Given this list of marker genes BDKRB2, BAK1, MIR146A, NOL3, SGK3, MIR222, HELLS, BOK (NCBI Gene Id 84558), PARK7, WFS1, NFE2L2, MMP9, TMEM161A, MAP2K1, SCRT2, SLC25A31, IL1B, USP47, TAF9, HSPA1B, ACVR1, TNF, RIPK1, PTTG1IP, DDIAS, C8orf44-SGK3, PPIA (NCBI Gene Id 5478), CTNNB1, TMBIM6, PEA15, ITGA6, TRIM32, PPIF, CTTN, MIR92A1, FGF2, QARS1, SYVN1, MIR21, RELA, RPS6KB1, BCL2L1, CTH, CSNK2A1, IKBKG, HTRA2, BMI1, PSMD10, TMBIM1, GHITM, GATA4, GDNF, TPT1, MIR19A, PINK1, MDM2, CTNNA1, STRADB, MARCHF7, WNT4, MAP2K5, ARHGEF2, MUC1, PLAUR, URI1, SH3RF1, HMOX1, ITGAV, PIK3CB, ELL3, BCL2, HIF1A, PELI3, GSTP1, IL7, NOC2L, CX3CR1, SRC, BID, ATAD5, TRAP1, DDX3X, ASAH2, NME5 (NME/NM23 family member 5), MIF, CSNK2A2, SERPINE1, CXCL12 (NCBI Gene Id 6387), FZD1, GPX1, HMGB2, BAX, PDX1, YBX3, COL2A1, OPA1, MIR199A1, SOD2, PRELID1, BRCA1, INS (NCBI Gene Id 3630), AATF, SIRT1, RTKN2, IFI6, IL1A, CREB3L1, PF4, MAGEA3, GATA1, RB1, SLC25A6, TCF7L2, HTT, YAP1, PCGF2, HIGD1A, RRM2B, ACKR3 (NCBI Gene Id 57007), PTPN1, CFLAR, NR4A2, FXN, TXNDC12, ZMYND11, SIAH2, LGALS3, THBS1, PHIP, CREB3, CSF2, MIR195, ATF4 (NCBI Gene Id 468), WNT1, SFRP2, WNT16, TRIAP1, NONO, FZD9, SELENOS, FGA, UNC5B, ITPRIP, ICAM1, RAF1, GCLM, ARMC10, KDM1A, IL10, SLC25A5, HDAC1, MCL1, BMP4, SCG2, LMNA, DNAJA1, SLC35F6, AKT1, MIR132, BMP5, FIGNL1, RACK1, FGG, MPV17L, BDNF, MIR142, ING2, MAPK7, EYA2, MAZ, TMEM14A, MIR221, SNAI2, CDKN2D, MAPK8IP1, NANOS3, FGB (NCBI Gene Id 2244), GSK3B, IGF1, PTGS2, IVNS1ABP, HSPB1, ZNF385A (zinc finger protein 385A), NOG, LRRK2, GRINA, NRG1, FYN, FBXO7, BIRC6, XBP1, BAG5, GFRAL, HYOU1, KLF4, EPO (erythropoietin), NOS3, AR, NRP1, FAIM, MIR17, TERT, PRDX2, EYA3, PSEN1, RRN3, PRKN, RFFL, HERPUD1, MIR29B1, GNAI2, CD74, ACAA2, BCL2L12, CCAR2, EYA1, MIR210, IER3, TGFBR1, RB1CC1, MNT, MIR133A1, CLU, PYCR1, TAF9B, CX3CL1, PSME3, CD44, PAK5, PARL, HGF, FGF10, TNFAIP3, SNAI1, EYA4, SLC25A4, PPEF2, IL19, ENO1, RNF34, FAIM2, GCLC, HSPA1A, MAPK8IP2, here is a description of the gene set: species: Homo sapiens Any process that stops, prevents or reduces the frequency, rate or extent of apoptotic signaling pathway. Human Gene Set: GOBP_NEGATIVE_REGULATION_OF_APOPTOTIC_SIGNALING_PATHWAY